Given this list of marker genes RPL13, FHIT, PIM2, NR2C2, NOC2L, MED30, ERCC6L, LAS1L, ZNF891, CCNQ, DUSP12, RPL39, HIRIP3, SRSF1, CENPT, TTC28-AS1, PPWD1, HELQ, TRIAP1, GFOD3P, CD96, CEACAM21, MTMR9LP, ATP5F1A, C14orf93 (chromosome 14 open reading frame 93), SRSF10, SEPTIN7P2, ZMYM5, TUSC2, SNRPN, USP16, TOMM20, NBDY, CCDC18-AS1, FANCD2 (FA complementation group D2), RHOH, WDR36 (WD repeat domain 36), LPCAT3, HSPH1, ZKSCAN2, CD2, METTL16, LINS1, RPS3, RPL36A, AMT, TP53TG1, SOX7, SLC41A1, LRRN1, FBH1 (F-box DNA helicase 1), MSL3, RPAIN, ZNF789, FAM136A, UBP1, RPLP2, DKK3, SEC31B (SEC31 homolog B, COPII coat complex component), CDIN1, RALGAPA2, TTPAL, JRKL, RPL38, MLLT3, MAP1B, CTBP1-AS, HSP90AB1, YTHDC1, NAT10, NOPCHAP1, ENSG00000277182, NOL7 (NCBI Gene Id 51406), NDUFAF6, PRPS1, NDUFAF4, RIOK2, PAN2, ANKRD36, EIF2S1, TUBE1, COG2, SPRR2C, ERCC5, WRN, KBTBD6, CERS6, UXT, JTB, QRICH1, RPUSD4, ACER1, KDM2A, C9, ZRANB3 (NCBI Gene Id 84083), REPS1, ATP5MC1, PUS3, ZNF778, RPL11, SETD6, CXorf58, SIRT3, RPL27 (NCBI Gene Id 6155), WDR59, PMPCB, MAPKAPK5-AS1, CFAP44, NSA2, EAPP, RPS10, NOB1, CIPC (CLOCK interacting pacemaker), PLXDC1, SERINC3, TMEM50B, POLR2J4, COQ9, KBTBD4, TMEM243, PSMA3-AS1, SFMBT1, TTC3, WDR33, CLK4, NOL6, TENT4A (terminal nucleotidyltransferase 4A), IFT70B, SNRNP40, VAPB, COIL, MIR99AHG (NCBI Gene Id 54079), PPT2, NUP88, CEP85L, NGRN, BTN1A1, RASA2, TMEM182, KLHL3, PVT1, NDFIP1, DLAT, PGBD4, CA6, RBM34 (RNA binding motif protein 34), TAF9, FGFR1OP2, SMIM27, CD8B, C14orf178, VRK1, CWC15, ARHGEF5, ACAD8, TIMM10B, CSTF2T, RPS29, PDRG1, ETFRF1, MYH3, TNRC6C, BCCIP, CFAP68, MED19, FOXO1, DQX1, ALG6, IMPACT, CCDC136, WRNIP1 (WRN helicase interacting protein 1), FBL, SLC25A38, MAGEH1, SAMD12, PFDN2, RPSA, ANAPC4, NUP133 (nucleoporin 133), BEX4, TRMT10C, SARNP, PNN (pinin, desmosome associated protein), FTSJ3, COQ5, RPL7, ZNHIT6, CXorf65, MAL, WRAP73, MPHOSPH10, MBD5, CDS2, KIAA2012-AS1, PAXBP1, NABP2, RXFP1, here is a description of the gene set: human blood monocytes were isolated, activated and harvested at several timepoints In this study, we identified genes that were differentially expressed in human monocytes activated with eiter NOD2L and/or TLR2/1L. from publication Schenk M, Krutzik SR, Sieling PA, Lee DJ, Teles RM, Ochoa MT, Komisopoulou E, Sarno EN, Rea TH, Graeber TG, Kim S, Cheng G, Modlin RL (PMID 22447076) Human Gene Set: GSE34156_NOD2_LIGAND_VS_TLR1_TLR2_LIGAND_24H_TREATED_MONOCYTE_DN species: Homo sapiens Genes down-regulated in monocytes (24h): muramyl dipeptide versus M. tuberculosis 19 kDa lipopeptide.